Given this list of marker genes ABCC9, ADAMTS13, KCNJ10, SLC34A1, STK39, KCNC1, SLC26A5, CRHBP, ATP1A2, SLC12A2, NEK7, DLG2, NPTX1, DLG4, CYP11B2, GNRH1 (NCBI Gene Id 2796), KMT2A, HSF1, CYP11B1, CACNA1H, SOD1, here is a description of the gene set: Human Gene Set: GOBP_RESPONSE_TO_POTASSIUM_ION Any process that results in a change in state or activity of a cell or an organism (in terms of movement, secretion, enzyme production, gene expression, etc.) as a result of a potassium ion stimulus. species: Homo sapiens